Given this list of marker genes Man1a, Edem3, Man1a2, Man2a1, Edem1, Man1b1, Man2a2, Man1c1, Edem2, here is a description of the gene set: Mouse Gene Set: GOMF_MANNOSYL_OLIGOSACCHARIDE_MANNOSIDASE_ACTIVITY species: Mus musculus Catalysis of the hydrolysis of the terminal alpha-D-mannose residues in oligo-mannose oligosaccharides.